The following is a description of a gene set: Binding to a sequence of adenylyl residues in an RNA molecule, such as the poly(A) tail, a sequence of adenylyl residues at the 3' end of eukaryotic mRNA. Mouse Gene Set: GOMF_POLY_A_BINDING species: Mus musculus, and this is the list of marker genes: Zc3h14, Rbms3, Pabpc4, Syncrip, Pabpc1l, Hnrnpdl, Elavl4, Eif4a3l2, Paip2, Rbms1, Pabpn1l, Khdrbs1, Pabpc4l, Pabpc5, Larp4, Pabpc1, Pabpn1, Ppie, Pabpc6, Paip2b, Pan3, Rbms2, Eif4a3l1, Eif4a3, D1Pas1, Ddx1, Hnrnpu, Khdrbs2, Pabpc2, Ddx3x